Given this list of marker genes PSMC3, PSMB3, TNKS, PSMB1, PSMC5, PSMA6, SEM1 (NCBI Gene Id 7979), CSNK2A2, RPS27A, PSMD12, PSMB4, PSMA4, AKT2, PSMD7, UBA52 (NCBI Gene Id 7311), PREX2, PSMA7, PSMD1, PSMD13, PSMD14, PSMC4, NEDD4, PSMC6, RNF146, PSMA5, PSMD11, PSMC1, PSMC2, WWP2, AKT1, OTUD3, PSMD8, PSMA1, PTEN, CSNK2B, PSMB7 (proteasome 20S subunit beta 7), AKT3, TNKS2, USP13, PSMA3, XIAP, PSMA2, TRIM27, UBB, CSNK2A1, PSMB6, ADRM1, PSMB2, STUB1, PSMD3, MKRN1, PSMB5, PSMD2 (proteasome 26S subunit ubiquitin receptor, non-ATPase 2), PSMD6, UBC, FRK, here is a description of the gene set: Regulation of PTEN stability and activity species: Homo sapiens Human Gene Set: REACTOME_REGULATION_OF_PTEN_STABILITY_AND_ACTIVITY